Given this list of marker genes ATP2B4, TRPV1, TACR1, TRPA1, HTR2A, P2RX2, KCNMA1, P2RX3, here is a description of the gene set: species: Homo sapiens Human Gene Set: GOBP_URINARY_BLADDER_SMOOTH_MUSCLE_CONTRACTION A process in which force is generated within smooth muscle tissue, resulting in a change in muscle geometry. This process occurs in the urinary bladder. Force generation involves a chemo-mechanical energy conversion step that is carried out by the actin/myosin complex activity, which generates force through ATP hydrolysis. The urinary bladder is a musculomembranous sac along the urinary tract.